Given this list of marker genes SLC6A8, MUSTN1, KIAA1755, IGFBPL1, ABCA1, LMOD3, HMGB2, CEMIP2, KIF2C, DEPDC1B, SRL, DIS3L2, CDCA8, ACTL6A, PTX3, PIF1, NPTX2, PSRC1, CCND2, DDC, FOXN3, NEUROD1, CD24, BIRC5, FAM83D, TRIM59, DOK5, MLLT11, SCARNA14, NRN1 (neuritin 1), ELAVL4, TAGLN3, RAP1GAP2, RGS4, SGO1, ZNF28, CELF3, ANOS1, ASPM, PMAIP1, ZMAT4, GPRIN3, KNL1, NKX2-3, ASB2, CDCA3, DEPDC1, TMSB15A, RPL13AP5, POU3F2, TP53TG1, HNRNPA1L2, HMGA1, VXN, RPS19 (NCBI Gene Id 8378), GNG5, HNRNPA1P1, LAMA5, RHOH, HEPACAM2, ASCL1, NCAPH, EFS, TNFRSF19, CLVS1, PRDX1, HJURP, RCOR2, SNHG5 (small nucleolar RNA host gene 5), PRMT8, DMRTA2, THSD7A, MSI1, TMEM169, KCNQ2, H3C7, NEUROG2, CELSR3 (NCBI Gene Id 1951), PDPN, MKI67 (marker of proliferation Ki-67), BOC, KIF15, HUNK, ADORA2A-AS1 (NCBI Gene Id 649503), DLL1, RPL23A, MAT2B (NCBI Gene Id 27430), KIF14, NES (NCBI Gene Id 79662), ENTREP2, PCBP4, MAGOHB, PCSK2, ZNHIT2 (zinc finger HIT-type containing 2), STMN1, NHLH1, TSPAN11, NEK2, RACGAP1 (Rac GTPase activating protein 1), RHOU, KIF23, TSPAN18, CHST1, FRMD5, FOXA2, SRRM4, TMEM132B, MYT1, NEUROG1, EPHB2, CRNDE, TMPRSS5, ASPA, SP5, INSM1, XIST, ATP8B5P, RTKN2 (rhotekin 2), EPB41, NDNF, TSIX, RFTN2, PDE1A, EPHA4, MAP6, PAK1, ELAVL2, H2BC9, DLGAP5, KLHDC8A, PIMREG, RPS14, PLK1, FBXW7, PRC1, IGF2BP1, DPH5, NUSAP1, CCND1, ARHGAP28, CRB1, TEAD2 (NCBI Gene Id 95515), ATP8A1, PHLDA1, FAM72A, COBL, GPSM2, ARL4A, GSE1, ADAMTS5, PROSER1 (proline and serine rich 1), AGO1, CDK1, CDC25B, CBFA2T2, CDKN1C, STK17B, ARHGAP11A, CADPS (calcium dependent secretion activator), TACC3, ZNF573, SGO2, PHF21B, WNT5A, ARK2C, CENPF, IGSF9, KIF4A, NUF2, MIR17HG, RPL36A-HNRNPH2, CCNB2, H3C2, PARPBP, UBE2C, PCDH8, TCF12, SEMA3A, BHLHE22, CKAP2L, PBK, SOX11, OTX2, POU3F1, NEUROD4, MSANTD3-TMEFF1, TP53I11, CCN1, TOP2A (NCBI Gene Id 7153), ZBTB18, CHN2, ST18, TUBB3, MAD2L1, MT1X, DLL3, DNAH2, GPC2, BRSK2, CCDC88B, PDE11A, GULP1, BUB1B, WNT7A (NCBI Gene Id 7476), BDH2, DCC, TFDP2, SOX2, FMN2, ZC3H12C (NCBI Gene Id 85463), GTSE1, KIF11, PPP1R17, HES6, EBF2, CCDC152, IGDCC3, MEGF6, DCX, HIC2, FNDC5, CCNA2, MIAT, ENO3, ANKRD13B, FREM2, MFNG, RPL18, TPX2, here is a description of the gene set: species: Homo sapiens Human Gene Set: MANNO_MIDBRAIN_NEUROTYPES_HNPROG Cell types are named using anatomical and functional mnemonics prefixed by 'm' or'h' to indicate mouse and human respectively: OMTN, oculomotor and trochlear nucleus; Sert, serotonergic; NbM, medial neuroblast; NbDA, neuroblast dopaminergic; DA0-2, dopaminergic neurons; RN, red nucleus; Gaba1-2, GABAergic neurons; mNbL1-2, lateral neuroblasts; NbML1-5, mediolateral neuroblasts; NProg, neuronal progenitor; Prog, progenitor medial floorplate (FPM), lateral floorplate (FPL), midline (M), basal plate (BP); Rgl1-3, radial glia-like cells; Mgl, microglia; Endo, endothelial cells; Peric, pericytes; Epend, ependymal; OPC, oligodendrocyte precursor cells. from publication La Manno G, Gyllborg D, Codeluppi S, Nishimura K, Salto C, Zeisel A, Borm LE, Stott SRW, Toledo EM, Villaescusa JC, Lönnerberg P, Ryge J, Barker RA, Arenas E, Linnarsson S (PMID 27716510)